Given this list of marker genes MIR4521, TMPO-AS1, GNA15-DT, RPL37A, XRCC1, LINC00112, ERFE, AP2A1, EEF1A1, UNC93B1, TJP2, UBA1, TXNP5, LTA4H, EPB41L4A, LINC02709, CKAP2, RFX2, RDH10, EAF2, RMI1, DNAJB2, MAP3K4, SPATS1 (spermatogenesis associated serine rich 1), SNUPN, TP53, PTMA, WNT5B, ZBTB7C, LINC01758, MFGE8, PYM1, TRMT2A, LIMA1, CLASP1, SAP30BP-AS1, ANKRD22, ASCC2, PNRC1, ITGB5, STAG2, UXT, DAGLB, RNU6ATAC32P, DDR1, CST9LP2, EPGN, MYO18B, TIGD2, PHLDB1, ARHGAP32, KMT2D, ZNF280C, KCNG3, CTXN2-AS1, SLC25A44, LRRC7, SNORD3A, EHD2, VAC14, ADD3, SIPA1L1, HRH1, FAM13A, PRKCE, PLEKHG3, CAPN8, MEMO1, HM13, COL6A2-DT, PAK6, LINC00240, LINC00963, LUARIS, PDHX, LTBP3, RNU6-1245P, BAZ2B, DOCK7, FAM149B1, RAPGEFL1, CSTA, SRRM3, RNVU1-14, GNG7, ENSG00000255476, MIR203A, PPAN, LINC02846, UXT-AS1 (NCBI Gene Id 100133957), SLC1A4, SH3RF2, POLDIP3, BCL3, NEAT1, CCDST, RCC1, ENSG00000268460, CROCC, SSH3, ANXA8L1, RNU4-1, WDR74 (NCBI Gene Id 54663), SNCG, TXNRD2, S100A2, LINC00111, TIA1, PDCL, SYT8, KAT6A, TMBIM6, ATP5MC3, LINC02739, ADGRB3, SQSTM1, CD200R1L-AS1, MANBAL, ZBED6, SMAD3, KRT8, MYOSLID, RNA5SP60, TASOR2, FMO9P, CTPS1, AK4, OR7A5, RANBP1, CLPP, GREB1, TBC1D22A, HEXIM1, ANKRD2, MYNN, RSU1, ENSG00000227496, ZNF184, APCDD1L, TMEM214, FAM76A, CCDC85C, VTRNA1-1, TRAF4, MGAT1, PRR15, KCNH2 (NCBI Gene Id 4027), PRIM1, SYTL1, MCC, ENO3, RAB11B, SERPINF1, LINC01350, EAF1-AS1, EIF4A1, PLEKHG4, MALAT1, LINC01503, LINC01181, PRKCH, DNMBP, TINAGL1, PFAS, RNU5B-1, TNFAIP3, VPS53, USP22, CHMP6, TRAJ7 (T cell receptor alpha joining 7), LINC01275, SCAMP4, ARPP19, RPL30P3, FAM8A1, USP3, CD36, HRAS, CTSD, DDR1-DT, TRAF7, SCNN1A, VIPR2, ACSL4, VPS72, TXNL1, PLB1 (phospholipase B1), MRPS31P4, SLC48A1, SRP68, DELEC1, PLEKHG1, GABARAPL2, PSMB3, MEGF10, LINC01932, PPIA, CD83, CXADR, ENSG00000257732, SNHG3, EIF5A2, PA2G4P4, VANGL2, LAMTOR3 (late endosomal/lysosomal adaptor, MAPK and MTOR activator 3), ANG (angiogenin), NPIPB8, BAIAP2, IGSF9, OMG, SSBP2, PLEKHF1, C17orf99, ACTR3B, HOMER3-AS1, PCCB, MIR7-3, SLC44A1 (NCBI Gene Id 63942), RNVU1-6 (NCBI Gene Id 101954276), ZNF395, SEMA4B, ICAM4, ANKFY1, MINDY1, RBBP8, ILF2, SFTA1P, RFFL, LAMA3, LZTS2, BARHL1, HTR5A, WDR26, PRUNE1, HMOX2, NAV1, EDEM1, MIR5087, ARRDC1, ADAM28, PALMD, SEMA3F, RPS29, PKM, EYS, ITPR2, EEF1A1P5, E2F7, BAP1, KRT7, NPAS1, LEMD1, TSPAN1, CIMAP2, LINC01920, EXTL3, SOCS5, TOR1A, RIMKLB (ribosomal modification protein rimK like family member B), ARHGAP24, RNVU1-21, RHOBTB2, TMBIM1, TRIOBP, FNDC11, FMN1, LINC02984, FAT3, DBI, INPPL1, LINC01919, NECTIN4, SLC25A6, RNU12, NLRX1 (NCBI Gene Id 79671), IFRD1, CAPS2, TMEM127 (NCBI Gene Id 84178), HNRNPU, EFCAB13-DT, S100A12, NDUFS4, NAA38, ARHGEF9, CCDC144A, SOX6, TRMT9B, XPO5, ACTR3-AS1, EHF, CORO1C, LINC01556, NDUFV2, DOT1L, LINC02136, STAG2-AS1, RGMA, AADACP1, LIMASI, MEIS2, CA13, LINC01531, PALS1, C8G, AMOTL1, PPP1R37, C1RL, HOPX, KATNBL1P5, MRPL35, UBE2E3, HHAT, PTPRF, HOMER3, PIWIL2, EML2, HPS1, VWC2L, RIC3, AP2A2, RNA5SP354, SMAD7, CTNNBIP1, TFEB, DNAJB4, MDM4, SEM1, TRIB1, DIAPH1, UCA1-AS1, TRIB3, LINC02336, FAM135A, OSGIN2, AGPS, C19orf25, LINC01229, CSAD, RNF43, ATG4C, SAMD1, VWA7, SUN1, TSKU, TMEM105, MVB12A, ZNF362, GATAD2B, ATP2A2, RRAS2, NANOS3, THADA, RPS7P1, RGS20, ADGRB2, RPS5, HEBP2, DOK7, BRWD1 (NCBI Gene Id 54146), MFSD4A, FAM83A, HCAR2, UBE4B, NXN, RNASE4, FOXO3, KRBA1, NCOA7, SUNO1, GRHL3, HOXA4, UNC13D, LINC00479, DAAM1, THOC7, TMPRSS4, CCNL1, RETREG3, EMC4, TRAPPC8, DAG1, WWTR1, FAT1, SLC35F2, PCSK7, ALDH16A1, PTPN11, ZC3H12A, ERCC1, TCEANC2, MRPS31P5, NABP1, MYCBPAP, ARNT, SPRY1, LINC00993, TKT, LINC00938, SRSF3, UGT1A6, RNA5SP402, DHODH, PIK3CA, SLC12A1, HNRNPD, KRT5, PHLDB2, AQP10, TMEM253, HJV, TTK, TESMIN, SCAT8, PIP4P2, TBL1XR1, POU2F3, USP34, IGF2BP3, CAPN1 (NCBI Gene Id 823), ZBTB17, PLEC, AURKAP2, RABEPK, CHEK2, COL7A1, ZFP62, CTXN2, EFNA1, ENSG00000204684, CLN6, ESRG, PCDH1, PTAFR, RNF39, YAP1, COA1, RCOR3, CASP4, PTPA, TRIP11, TJAP1, NICN1, PPP2R5A, LINC03033, MORF4L1, PITPNM1, TMEM200B, SSBP3, GSTA4, MYOT, S100A11, CCM2, TMEM40, VARS2, MT2P1, LINC01719, CDHR2, RBBP8NL, HMGN4, YTHDF2, SH3PXD2A-AS1, COQ8B, GHITM, DHRS3, EPB41L2, LINC01133, PPARGC1A (NCBI Gene Id 10891), RNU4ATAC, HR, MTND5P11, MIDN, RNU6-925P, PMVK, DIS3L2, IFI16, DST, GRSF1, HIVEP1, KMT2A, SPIN1, SLPI, MIR3649, EIF2S3, RPA3, ZNF219, YBX3, RPL32P30, PLXNA3, TRIM29, C15orf62 (chromosome 15 open reading frame 62), RPS21P4, RICTOR, ZBTB20, SNORA48, ABHD17C, STX19, VTRNA1-3, LINC01704, SYNCRIP, ICMT (NCBI Gene Id 57087), FASTKD5, PCF11, SH3PXD2B, RFX1, PLEKHG2, PTPN9, NAV2, PRKCD, LINC02354, AKAP6, COTL1, SBDS, HAP1, CXXC4, GDF15, ATP8B1, PTGS2, NSMAF, CPVL, HSD17B3, AK5, MYL12B, TYW1 (tRNA-yW synthesizing protein 1 homolog), RNU4-2, POTEH, AJUBA, MIR7-3HG, NFKBIA (NCBI Gene Id 4792), ATP5MGP8, GTPBP3, ABCC3, LINC02868, GARNL3, RNU5A-1, MRPL54, DLC1, ACTN1, FAM230G, XDH, FRMPD2, CCAR2, MLLT1, MCF2L2, MTA3 (NCBI Gene Id 731342), RBIS, HBP1, RAC1, ZNF839, HRCT1, LINC02098, ENSG00000266401, LFNG, MIR4492, EVPLL, CBX3, OR7E104P, PHF19, LINC01962, FRMD4B, VGF, LRRC28, GPC1, UBE2E3-DT, ZMYND8, SNAP25-AS1, OR10AC1, CUL3, BMP1, BEX2, STK25, USP40, MYH9-DT, SPTBN2, RBM17, NDST1, ATP1A1, MPG, NIBAN2, FRAT2, OR9G1, SMARCD2, ABCB5, SSBP3P5, HIVEP2, CD82, RBM39, RAB40AL, PTPN11P4, RNA5SP334, LRRFIP2, FBXO27, MAL2, WNT10A, TNIP1, ABCA10, ARNT2, PLXNB2, PGK1 (NCBI Gene Id 5230), IKBKB-DT, NDUFAF5, ESCO1, LINC02541, PRKCE-AS1, C2orf76, CSNK1E, STAU2-AS1, C2orf42, RPRD1A, ZNF76, BRD2, CDC42EP1, SMAD6, WSB2, SPMAP2, PRSS22 (serine protease 22), ERP27, RNU6-1, ENSG00000253452, RNU6-100P, MED24, MYH9, GAD1, DYNLL1, CCNE1, GADD45GIP1, MPIG6B, NRP1, OVOL1, AXL, RAPGEF5, PATJ, CFDP1, MARCKSL1P2, LONRF3, FAM222A, GTF2H4, ZNF638, ZFAT, CLDN6, TMPRSS11F, HEATR3, LASTR, TLE4, SPAG4, RNF24, PROSER2-AS1, SPATA12, PDCL3, MPZL2, SLC2A1, ENSG00000267174, TMEM95, MR1, SMAD3-AS1, PACERR, EGFR, TGFBI, CABLES2, TRIM7-AS2, ANK2, CDK5RAP2, FBXW5, RAD23B, MIR2117HG, PHACTR4, MTUS1, LIMS1, ANXA8, SAA1, TBL1X, MFAP5, RHBDF1, ALDH3B2, NCAM2, ELF4, FHOD3, MBNL3, PPM1L, HNRNPK, GABRE (gamma-aminobutyric acid type A receptor subunit epsilon), RNU6-380P, TNRC18, BMI1, COMT (catechol-O-methyltransferase), TRABD, EHD1, ARHGEF19, ETV4, CUEDC1, NRF1, DERA, FAM83B, DYNLRB2-AS1, CCR3, LRP5L, TIPARP, MIR4999, NFE2L2 (NFE2 like bZIP transcription factor 2), ENSG00000250685, MDFI, RNU6-263P, EPDR1, RNF214, CLCA4, KLK9, LPP, GSE1, PINLYP, RAB3IP, CFAP418, LINC01671, SIL1, BAG3, TPST2, LINC01588, USP31, RPL31P43, SLC44A2, FLNA, SLC37A2, LINC01623 (NCBI Gene Id 401242), HSD17B6, HNRNPD-DT, B4GALT6, MRPL45P2, ITPRIP-AS1, ITGA3, WDPCP, USP34-DT, CASTOR1, RPL35AP, DNAAF5, RPS26P29, SLC46A1, NREP, RPL39P5, ENSG00000233017, NDST1-AS1, LINC02934, TRPV3, RN7SKP192, RXRA, DCLK1, CYB5R1, ADAM10, PLD1, ENSG00000257746, LINC02205, SERPINB13, ERCC4, NECTIN4-AS1, ENSG00000266088 (NCBI Gene Id 105371773), ABCB9, HK1, H3C9P, ZFAND6, KRBA2, TYSND1, UBE2V2, PLOD2, IQANK1 (IQ motif and ankyrin repeat containing 1), KCTD1, PCDH9, SEPTIN9, TTI2, GPR141, COL6A2, AKIRIN1, RNVU1-27, PPAN-P2RY11, APBA3, RGS17P1, CCNT1, MIR5684, KNL1, DDX60, CNIH3, NMRAL1, PBX1, SMU1, ANKRD11, ATXN10, LINC01144, UBOX5, RNU11, MTA2, ZNF746, SGK1, PHYHIP, ADAT3, ATF7IP2, XXYLT1, DUSP6, KLK6, ENSG00000265246, RNY1, CDH23, FAM193A, RHOBTB3, KDSR, XKR8, NDUFS7 (NCBI Gene Id 4727), RNF217, SBNO2, GHET1, ATP2C1, EPCAM, MACROD2, here is a description of the gene set: from publication Yevshin I, Sharipov R, Kolmykov S, Kondrakhin Y, Kolpakov F (PMID 30445619) studied in species Homo sapiens Human Gene Set: KMT2D_TARGET_GENES Genes containing one or more binding sites for (KMT2D) in their promoter regions (TSS -1000,+100 bp) as identified by GTRD version 20.06 ChIP-seq harmonization.